Given this list of marker genes Actr5, Abcg5, Atp8a2, Ddb2, Cacna1c, Gpr52, Rom1, Kras, Irx6, Mtch2 (NCBI Gene Id 80443), Ercc8, Gnat3, Bcl3, Chek2, Plk3, Tmem109, Egr1, Nts, Agrp, Mmp3 (matrix metallopeptidase 3), Sct, Hyal1, Mmp2, Rhbdd1, Kit, Wrn, Sprtn (NCBI Gene Id 244666), Bard1, Babam2, D7Ertd443e, Yap1, Sod2, Rgs9bp, Brca1 (NCBI Gene Id 12189), Bmyc, Abraxas1, Elk1, Cul4a, Cacnb4, Atoh7, Ckap5, Ttc36, Map4k3, Cabp4, Rhob, Pianp, Aurkb, Rgs9, Guca1b, Tulp1, Kat5, Large1, Bax, Chrd, Mmp9, Htt, Mfap4, Atxn1, Rrh, Sema5a, Sirt1, Mapk14, Pold1, mt-Nd3, Usp1, Hrh1, Cdkn1a, Ap1s2, Opn5, Neto1, H2ax, Comt, Reep6, Rnf168, Nipbl, Cry1, Yy1 (NCBI Gene Id 22632), Pik3r1, Rrm1, Asns, Casp7, Pde6d (phosphodiesterase 6D, cGMP-specific, rod, delta), Nabp2, Ifi206, Mmp1b, Col6a2, Th (tyrosine hydroxylase), Cdkn2d, Ifi214 (NCBI Gene Id 545384), Ccnd2, Fos, Il12b, Rcvrn, Fbxo4, Cdk5, Ccl7, Xpc, Clk2, Map3k20, Rbx1-ps, Gucy2f, Nabp1, Rbp4 (retinol binding protein 4, plasma), Gngt1, Tyr, Mc1r, Nptn, Ifi203-ps, Ift20, Ddhd2, Usp2, Slc4a10, Foxb1, Rpe65, B4galt2, Tafa2, Casp9, Casp3, Zranb3, Ppp1cc, Itgb6, Paxip1, Ppid, Tlk2, Rad23a (RAD23 homolog A, nucleotide excision repair protein), Slc1a3, Dcun1d3, Grb2, Gpr88, Zbtb1, Rev1, Cntnap2, Nscme3l, Tipin, Nlgn3, Tnf, Rpain, Pclaf, Tuba1a, Aipl1, Chrnb2 (cholinergic receptor nicotinic beta 2 subunit), Gnb5, Nucks1, Pcna, Ext1, Sfrp1, Ctns, Agap3, Brat1, Lrit3, Trp53i13, Per1, Tmem161a, Lrrn4, Primpol, Hmgn1, Nf1, Cds2, Cngb1, Parp1, Msh2, Nr2f6, Ro60, Idua, Prph2, Fbxw7, Trp53bp1, Ei24 (etoposide induced 2.4 mRNA), Rnf8, Blm, Pola1, Crhr1, Il12a, Mrnip, Eya3, Nlrp1a, Ddias, Lrp2, Rad51ap1, Ruvbl2, Cpt1b, Atm, Ptprk, Gpr179, Nps, Ppp1ca, Grm6, Kmt2a (lysine (K)-specific methyltransferase 2A), Drd5, Nlrp1b, Pde6c, Meis2, Aen, Slc24a4, Ect2, Dynlrb1, Grin2a, Rfwd3, Smc1a (NCBI Gene Id 80490), Krt14, Cyp2r1, Xpa, Ppp1r1b, Mbd4 (NCBI Gene Id 17193), Tanc1, Ifi207, Deaf1 (DEAF1, transcription factor), Tnks1bp1, Slc7a11 (NCBI Gene Id 99638), Ercc3, Akt1, Ercc6 (excision repair cross-complementing rodent repair deficiency, complementation group 6), Uimc1, Ercc4, Ercc2, Gtf2h5 (NCBI Gene Id 72566), Mapk8, Ghrl, Pnp, Kcnc2, Egfr, Dcdc2a, Fech, Abl2, Pias1, Cdc25a, Gh, Mndal, Ndrg4, Ticrr, Kcne1, Trp53inp1, Dbh, Trp53bp2, Brca2, Lig4, Gata3, Ercc5, Bbs10, Il1a, Smpd1, Apobec1, Gpx1, Fancd2, Topbp1, Zzef1, Sgk1, Net1, Rad54b, Nog, Hif1a, Gadd45a, Aanat, Col6a3, Ifi213, Star, Eya1, Opn1sw, Noc2l, Bhlhe40, Xrra1, Babam1, Cop1, Nsmce3, Eif2s1, Rad18, Atp1a3, Abcc8, Kdm1a, Ddb1, Sde2, Rad9b, Myo15a, Fignl1, Hmgcr, Bmf, Ercc1, Brcc3dc, Uaca, Rag1, Mapk13, Triap1, Txn1, Mapk9, Prkdc, Cul4b, Thbd, Col6a1, Polh, Braf, Itgb1, Opn1mw, Cacna1f, Usp28 (ubiquitin specific peptidase 28), H2aj, Cdkn2a, Mettl3 (methyltransferase 3, N6-adenosine-methyltransferase complex catalytic subunit), Ube2a, Cxcl2, Lrit1, Cryaa, Ptprc, Kars1, Pnpla2, Fbxl21, Fbxl3, Npm1, Gnat1, Grin1, Men1, Kcnc1, Opn4, Tgfb1, Sfrp2, Rgs14, Xrcc2, Cbl, Usf1, Mtor, Creb1, Ivl, Brcc3, Rp1, Cirbp, Cep250, Rad54l, Rpl26, Rbx1, Frmpd1, Inip, Timp1, Trp53, Gnat2, Ccar2, Pold3, Dct, Pcare, Msh6, Ifi208, Ogg1, Slc1a2 (solute carrier family 1 (glial high affinity glutamate transporter), member 2), Aqp1, Polk (polymerase (DNA directed), kappa), Rad51, Drd3, Sdf4, Snai2, Adam2, Mapk11, B3gat1, Sik1, Xrcc5, Id2, Cck, Ino80, Ccnd1, Gpsm2, Hsf1, Ifi209 (NCBI Gene Id 98348), Map3k4, Prkcd, Drd2, Xrcc6, Tigar, Trex1, Syngap1, Col3a1, Mmp1a, Drd1, Atr, Uvssa, Myc, Rdh13, Pde8b, Lcn10, Pln, Bcl2, Rho, Opn3, Ube2b, Clock, Rhno1, Cers1, Fancg (Fanconi anemia, complementation group G), Brsk1, Akt2, Rbm4b, Trim32, Rad23b, Zmpste24, Ric8a (RIC8 guanine nucleotide exchange factor A), Hus1, Hras, Poli, Mapk10, Best1, Nhej1, Crtc1, Asic2, Rbm4, Map2k7, Pparg, H2ac25 (NCBI Gene Id 319162), Tank, Ppp1cb, Stk11, Alad, Ccdc66, Cops9, Ep300, Pde1b, Hrh2, Adra1b, Pbk, Ifi203, Bcl2l1, Cacna2d4, Ube4b, Mta1, Gja10, Arrb1, Rnf4, Rela, Ints7, Rpgr (retinitis pigmentosa GTPase regulator), Guca1a, Swi5, Dtl, Eef1d, Ccl2, Atp1a2, Pmaip1, Ints3, Sema5b, Grk1, Abca7, Dhx36, Per2, Eif2ak4 (eukaryotic translation initiation factor 2 alpha kinase 4), Elane, Kdm4d, Ttr, Mme, Pcp2, Sirt6, Crb1, Prap1, Pml, Trpm1, Bak1, App, Hoxa1, Cacna1e, Mecp2, Crip1, Nfatc4, Spidr, Nek1, Cryab, Nedd4, Synpo, Hyal2, Mdm2, Pierce1, Bbc3 (NCBI Gene Id 170770), Rad1, Cat, Hyal3, N4bp1, Scn11a, Dnmt3a, Rgr, Prkaa1, Per3, Dclre1c, Xrcc4, Cry2 (cryptochrome circadian regulator 2), Polb, Tspyl5, Rad9a, Crebbp, Pde6b, Gnb1, here is a description of the gene set: Any process that results in a change in state or activity of a cell or an organism (in terms of movement, secretion, enzyme production, gene expression, etc.) as a result of an electromagnetic radiation stimulus. Electromagnetic radiation is a propagating wave in space with electric and magnetic components. These components oscillate at right angles to each other and to the direction of propagation. species: Mus musculus Mouse Gene Set: GOBP_RESPONSE_TO_RADIATION